Given this list of marker genes APLN (apelin), MTDH, MEST, CAPS2, GGA3, ATP8B3, MRFAP1, GLYAT, FKBP15, C9orf153, CHODL, RSBN1, SHANK2, WDR47, LARS1, ERRFI1, EEA1, TMEM169 (transmembrane protein 169), EXTL1, RAB2B, ATP6V0E1, ATP8A2, ZNF337, GCC1, SYNCRIP (NCBI Gene Id 10492), NUP188 (nucleoporin 188), MIEF1, RB1CC1, GSTA2, SHISA7, PTPRB, MAP3K7, ELOVL1, ESR1, HECW2, IFI44L, CLIP4, RTF2, GRM7, SQSTM1 (NCBI Gene Id 94002), CLCA2, SRP9, ECHDC1, LYRM1, GATAD2B, PSRC1, RPAIN, ITGB1BP1, DNAJC21, PTS, here is a description of the gene set: studied in species Homo sapiens from publication Chen Y, Wang X (PMID 31504780) Human Gene Set: MIR6821_3P Genes predicted to be targets of miRBase v22 microRNA hsa-miR-6821-3p in miRDB v6.0 with MirTarget v4 prediction scores > 80 (high confidence targets).